The following is a description of a gene set: studied in species Homo sapiens Renal cortical microcysts Cysts of microscopic size confined to the cortex of the kidney. Human Gene Set: HP_RENAL_CORTICAL_MICROCYSTS, and this is the list of marker genes: INVS, PEX1, PEX2, SKIC3 (NCBI Gene Id 9652), NEK8